Given this list of marker genes Fbn2, Hycc1, Glrb, Rapgef6 (NCBI Gene Id 77527), Stk3, Rest, AU041133, Gmps, Coro1c, Atxn7, Hivep3, Rbfox1, Slc4a4, Spryd7, Fndc3b, G6pc1, Calcoco1, Cadps2, Adgrb3, Tmtc4, Phc3, Ivns1abp, Ppm1f, Ttpa, Atp1b1, Atp11c, Zfp711, Rbsn, Nfat5, Ppp4r1, Kras, Runx2, Tbca, Serpinb9, Spice1, Med17, Dach1, Kcnh5, Abcd2, Zc3h12c, Mkrn3, Adamtsl3, Cstf3, Zfp600, Cdyl2, Hnf1b, Klf12, Ppm1d, Nap1l2, Gxylt1, Wapl, Vat1l, Tet2, Zfp980, Mier3, Acer3, Dnaja1, Tmem135, Porcn, Dars1, Pard3b, Asap1, Sema3a, Kctd9, Olr1, Ubl3, Aqp4, Slc38a2, G3bp2, Rrm1, Ptpn4, Rtf1, Zfp981, Hspa9, Rex2, Tiam2, Lrriq3, Kctd5, Esco1, Ezh2, Vsnl1, 1700010I14Rik, Crls1, Lin9, Chst11, Zbtb21, Foxo1, Psip1, Slc66a3, Supt20, Dnajc18, Mast4, Gpm6a, Stat1, Stt3a, Or5d38, Chsy1, Ctdspl2, Chn2, Anln, Zfp820, Kmo, Picalm, B230219D22Rik, Mtmr7, Chac1, Sel1l, Hsbp1l1, Klhl15, Fign, Msn, Dock3, Usp27x, Bcl11a, here is a description of the gene set: studied in species Mus musculus Mouse Gene Set: MIR_217_5P Genes predicted to be targets of miRBase v22 microRNA mmu_miR_217_5p in miRDB v6.0 with MirTarget v4 prediction scores > 80 (high confidence targets). from publication Chen Y, Wang X (PMID 31504780)